Given this list of marker genes AASS, SLC7A7, NADK2, SLC3A1, SLC7A9, here is a description of the gene set: species: Homo sapiens Hyperlysinuria An increased concentration of lysine in the urine. Human Gene Set: HP_HYPERLYSINURIA